Given this list of marker genes Ppp3cc, Ctdsp1, Dusp4, Dusp3, Pdxp, Cdc25a, Ptprz1, Ptpro, Ptprn2, Ppp1cb, Ptprt, Ppm1e, Ptp4a3, Ptpmt1, Ptprs, Eya1, Ssh2, Ppm1h, Dusp7, Ppm1m, Ppm1a, Eya4, Ptp4a1, Mtmr3, Acp3, Dusp23, Ctdnep1, Ptpn3 (protein tyrosine phosphatase, non-receptor type 3), Ppef2, Cdc25c, Ssh3, Ptpn6, Ppp3cb, Ppp1cc, Dusp21, Ptpru, Ptpn18, Ppm1n, Pgam5, Dusp26, Cdc14a, Cdkn3, Tns2, Ppm1g, Ptprr, Ppp5c, Ptpn4, Dusp14, Dusp29, Ppm1k, Ppp4c, Ptpn14, Dusp19, Ppp1ca (NCBI Gene Id 19045), Pten, Ublcp1, Ptpre, Phlpp1, Dusp13a, Ptpn21, Ppm1b, Cdc25b, Pgp, Epm2a, Phlpp2, Eya2, Ptpn20, Eya3 (NCBI Gene Id 14050), Ptpn22 (protein tyrosine phosphatase, non-receptor type 22 (lymphoid)), Ppm1d, Mdp1, Cdc14b (CDC14 cell division cycle 14B), Ppp2cb, Ptpn5, Dusp28, Ptpn13, Ptpn7, Ctdspl, Ptpn12, Ctdsp2, Ssh1, Dusp18, Ppm1f, Ptprk, Ctdp1 (NCBI Gene Id 67655), Ppp2ca, Mtmr4, Ssu72, Dusp22, Ppp6c, Dnajc6, Pptc7, Ptprq, Ptprm, Dusp12, Ubash3b, Rpap2, Ptpn1, Dusp10, Ptprv, Dusp8, Dusp15, Ptprb, Ilkap, Ptpra, Ppef1, Ptpn23, Cpped1, Ppp3ca, Ptprd, Dusp2 (NCBI Gene Id 13537), Ppm1j, Ptprj, Ptpn2, Dusp1, Ptprf, Dusp13b, Dusp6, Ptp4a2, Ptprg, Ptprc, Ptprh, Ptpn11, Acp1, Ptpn9, Ppm1l (NCBI Gene Id 99867), here is a description of the gene set: Mouse Gene Set: GOMF_HISTONE_PHOSPHATASE_ACTIVITY studied in species Mus musculus Catalysis of the reaction: a phosphorylated histone + H2O = a protein + phosphate.